The following is a description of a gene set: Activation of the Mitogen activated protein kinase (MAPK) cascade following Toll-like receptor (TLR) stimulation enables innate immune cells to rapidly activate cytokine gene expression. A balanced response to signals of infectious danger requires that cellular activation is transient. Here, we identify the MAPK phosphatase Dual specificity phosphatase-1 (DUSP1) as an essential endogenous regulator of the inflammatory response to LPS. DUSP1-deficient (DUSP1-/-) bone marrow derived macrophages showed selectively prolonged activation of p38 MAPK and increased cytokine production. Intraperitoneal challenge of DUSP1-/- mice with LPS caused increased lethality and overshooting production of IL-6 and TNF-alpha. Transcriptional profiling revealed that DUSP1 controls a significant fraction of LPS-induced genes, that includes IL-6 and IL-10 as well as the chemokines CCL3, CCL4 and CXCL2. In contrast, the expression of the important mediators of endotoxin lethality, IFN-gamma and IL-12, was not significantly altered by the absence of DUSP1. These data together demonstrate a specific regulatory role of DUSP1 in controlling a subset of LPS-induced genes that determines the outcome of endotoxin shock. from publication Hammer M, Mages J, Dietrich H, Servatius A, Howells N, Cato AC, Lang R (PMID 16380512) Human Gene Set: GSE3565_DUSP1_VS_WT_SPLENOCYTES_POST_LPS_INJECTION_UP Genes up-regulated in spleen from mice injected with LPS: DUSP1 knockout versus wildtype. studied in species Homo sapiens, and this is the list of marker genes: NUP160, MYB, MYC, ARHGAP9, PRPS2, IL2, PLEKHA1, TTLL12, RPL29, GPHN, SELL, CCDC162P, NMD3, NXPE1, SOCS3, PGF, RPS10 (NCBI Gene Id 6204), RPS5, PLCB2, INTS1, GLUD1, FAN1, PHF12, MIPEP, RLIM, MDN1, RPL27, ETNK1, KGD4, CIAO2A (cytosolic iron-sulfur assembly component 2A), NUP155, SEC61A2, PARP8, CBL, TRAF1, HSPA9, AKAP10, AHCY, POLR1F, PIM2, TENT5A, ACTN1, PRDX6, TREML2, COMMD2, SNRK, IPO4, POLE2, SRM, DKC1, CSNK1G3, SND1, TMEM154, NCOA6, ASB15, MAGOHB, PDS5B, TAF1D, PRMT3, MTHFD1, CDH1, PURB, TNFSF8, SCAPER, WDR77, ADAM19, PATJ, IL6ST, RCL1, EIF3J, EEF1B2, RPS15A, ADGRL3, LYST, ATP11B, ABLIM1, RPL17, TMEM38B, CSNK1E, INSR, RPL19, SZT2, CCNL2, PDK1, SIDT1, TTC13, PPP1R3C, ATP5F1C, HTATSF1, SSBP2, CDK5RAP1 (NCBI Gene Id 51654), ARHGEF1, PA2G4, BTLA, INPP4B, RPL24, TNFAIP8, GNL3, RPS26, RPLP0, DAPL1, POLR3E, AEN, TSEN2, EIF3H, RPL35A, NEDD4L, THUMPD2, RETREG1, CLEC2D, AKAP9, BRD4, RPL23A, RPL36, RPL18, RPL36A, EMD, TASOR2, NEURL3, UTP4, RPLP1, RPS15, MRE11, CLDND1, RPS2 (ribosomal protein S2), RPL13, NIFK, AKAP13, PPP4R3B, MYOZ1, RPL10A, RPL8, CCR7, RNF144A, TLR6, AFP, CSNK1G1, NFATC2IP (NCBI Gene Id 84901), GSTP1, ZSCAN12, DDX3Y, BICDL1, U2AF2, FCHSD2, HNRNPU, NPM1, RPL32, FAAH, LTV1, AGPAT5, IKBKE, NEFH (NCBI Gene Id 4744), FRMD8 (NCBI Gene Id 83786), THADA, GPR15, TLR1 (toll like receptor 1), VPS13A, IFRD2 (NCBI Gene Id 7866), NSG2, RAPGEF6, ERAP1, SPINK8, RPS20, RCN3, XCL1